Given this list of marker genes LRSAM1, SNX18, RALB, SNX4 (NCBI Gene Id 8723), WIPI1, ULK1, PIP4K2A, BECN1, SH3GLB1, RAB3GAP1, SNX30, PIP4K2C, TRIM32, MOAP1, ELAPOR1, RAB3GAP2, PIP4K2B, SNX7, ATG2A, WDR45, here is a description of the gene set: Any process that activates or increases the frequency, rate or extent of autophagic vacuole assembly. studied in species Homo sapiens Human Gene Set: GOBP_POSITIVE_REGULATION_OF_AUTOPHAGOSOME_ASSEMBLY